The following is a description of a gene set: Human Gene Set: WP_CORTICOTROPINRELEASING_HORMONE_SIGNALING Corticotropin-releasing hormone signaling species: Homo sapiens, and this is the list of marker genes: TBX19, NR4A1, ARRB1, ARRB2, GNB5, MAP3K5, CAMK2A, LINC02210-CRHR1, ECE1, NCOA2, NR4A2, NFKB1, GNAZ, RAF1, KRT1, IL2, BCL2, GJA1, HSD3B2, FOSL1, POMC, GNB3, SULT2A1, JUP, NOS3, TRIM28, IVL, FOSB, HSD3B1, CRH, GNB1, ELK1, CACNA1H, GNAI2, RELA, GNAS (GNAS complex locus), FOS, CXCL8, IL18, RAPGEF3, MAPK14, GNAI1 (G protein subunit alpha i1), PRKCD, PLCG1, RAP1B, PRKCQ, TCF4, GNB2, GNA11, GRK3, FOSL2, MAPK1, GNAQ, CASP3, STAR, TLR4, PRKAA2, MAPK8, CYP21A2, JUND, PRKCB, PRKCI, CASP9, MAPK3, CRHR1, NFKBIA, CREB1, HSP90AA1, CYP11B1, MAPK9, ERN1, TFAP2A, JUNB (NCBI Gene Id 90482), KRT14, CTNNB1, RHOA, BRAF, TGFB1, AKT1, GRK6, ACACA, SP1, CRHR2, GSK3B, GNAO1, PLCG2, MAP2K1, PRKCA, PARP1, CRHBP, CYP11A1, PTK2